The following is a description of a gene set: studied in species Mus musculus This event has been computationally inferred from an event that has been demonstrated in another species.<p>The inference is based on the homology mapping from PANTHER. Briefly, reactions for which all involved PhysicalEntities (in input, output and catalyst) have a mapped orthologue/paralogue (for complexes at least 75% of components must have a mapping) are inferred to the other species. part of: Toll-like Receptor Cascades electronically inferred by orthology from the curated human pathway Reactome Pathway: Regulation of TLR by endogenous ligand, and this is the list of marker genes: Ly96, Cd36, Apob, Fgg, Tlr4, Tlr7, Cd14, Sftpd, Tlr1, Hmgb1, Tlr2, Gsdmd, Lbp, Tlr6